The following is a description of a gene set: Human Gene Set: GOBP_POSITIVE_REGULATION_OF_ADAPTIVE_IMMUNE_RESPONSE species: Homo sapiens Any process that activates or increases the frequency, rate, or extent of an adaptive immune response., and this is the list of marker genes: HLA-A, PVR, TNFSF13, MAD2L2, BRD4, PRKCQ, AKIRIN2, ULBP3, B2M, IL18, MAP3K7, HLA-F, PAXIP1, ULBP1, IL12B, RAET1L, SLAMF1, FCER2, KMT5C, RAET1G, HLA-DRB1, HLA-B, MSH2, FADD, SECTM1, PYCARD, HLA-DRB3, IL23R, PTPRC, FCGR1A, CD226, TP53BP1, BRD2, TNFSF13B, CD1B, GATA3, HLA-H, LTA, TBX21, ZP3, HLA-C, IL18R1, CYRIB, OPA1, HSPD1, MALT1, HLA-E (NCBI Gene Id 3133), CD4, MR1, TRAF6, AZGP1, ZBTB1, IL12A, KLHL22, CD40, TAP2, SKAP1, EP300, NLRP3 (NLR family pyrin domain containing 3), FOXP3, IL6ST, CD81, ARID5A, SLC22A13, PMS2, CD1D, CD1A, TREM2, RAET1E, CD55, STAT6, FCER1G, NECTIN2, FBXO38, FZD5, EIF2AK4 (eukaryotic translation initiation factor 2 alpha kinase 4), TNF, MIR21, SASH3, SHLD3, NLRP10, EXOSC6, CD7, RSAD2, SIRT1, YWHAG, SHLD2, ADA, EXOSC3, ULBP2, NFKBID, ATAD5, HMCES, TRAF2, SLC11A1, P2RX7, IL4, JAK2, IL23A, NSD2, TGFB1, TNFSF4, CLEC6A, XCL1, BTK, RIF1, CLCF1, CCR2, RIPK2, CARD9, PRKCZ, HPX, C3, CD1C (NCBI Gene Id 911), KMT5B, DENND1B, IL1R1, C17orf99, IL6, HLA-G, IL1B, CD28 (NCBI Gene Id 940), CLEC7A, NFKBIZ, TFRC, PRKAA1, IL2, CD1E, IL12RB1, IL27RA, SHLD1, PLA2G4A (phospholipase A2 group IVA), HLA-DRA, STX7, MLH1, TYK2 (NCBI Gene Id 7297)